Given this list of marker genes NUP107, FGD1, POLR3A, NR5A1 (nuclear receptor subfamily 5 group A member 1), LEP, SPIDR, MRPS22 (NCBI Gene Id 64953), POLR3H, FSHR, ESR1, PNPLA6, CDKN2A, ANOS1, GCNA, DHX37, FKBP6, CPE, CHD7, ZFPM2, GNRH1, ALMS1, TERT, FGF8, MAP3K1, WT1, NFKB2, GDF9, PROKR2, CTNNB1, SPRY4 (sprouty RTK signaling antagonist 4), SOX9, CYB5A, FOXL2, NNT (NCBI Gene Id 23530), B4GALNT1, XRCC2, BMP15, NR0B1, AR, SOHLH1, BMP6, TP53, FEZF1, PSMC3IP, ZSWIM7, RBM28, TRAF7, STAG3, SUFU, STAR, HS6ST1, EIF2B1, MSH4, TAC3, NSMF, BNC1, LEPR, ZMYND15, PROK2, LHB, TXNRD2, POLA1, CYP11A1, SMARCB1, SMO, MAB21L1, SMARCE1, AKT1, SLC39A4, FGFR1, NR3C1, INSR, GNRHR, TACR3, PIK3CA, TAF4B, DCAF17, GATA4, HROB, WWOX, DUSP6, MC2R, HFE, TP63, DMXL2, BAP1, SEMA3A, NHLH2, CEP112, SYCP2L, NDNF, LGR4, MCM9, FANCM, LARS2, FGF17, ZNRF3, WNT4, VAMP7, KISS1R, NR2F2, CYP17A1, KISS1, GNAS, ALG6, WDR11, CYP11B1, POR, DHH, SPATA22, PDGFB, CTDP1, SYCE1, NF2, PRKAR1A, HSD3B2, ESR2, BTG4 (BTG anti-proliferation factor 4), FSHB, SRY, MRAP, here is a description of the gene set: Any deviation from the normal concentration of a sex hormone in the blood circulation Human Gene Set: HP_ABNORMAL_CIRCULATING_SEX_HORMONE_CONCENTRATION Abnormal circulating sex hormone concentration studied in species Homo sapiens